The following is a description of a gene set: Human Gene Set: HP_GENERALIZED_MUSCLE_WEAKNESS Generalized muscle weakness studied in species Homo sapiens Generalized weakness or decreased strength of the muscles, affecting both distal and proximal musculature., and this is the list of marker genes: SDHAF1, HADHB, AARS2, PON1, CLCNKB, MAP3K20, RNU12, LAMB2, BAG3, TAF15, VCP, MYH7, SLC2A3, TTN, CAPN3, HTT, SLC16A2, MORC2, AIFM1, RYR1, SLC25A1, PLOD1, CHMP2B, HADHA, FKRP, COL12A1, MATR3, SCN4A, RANBP2, ANXA11, COLQ, CHAT, GAA, VAPB, TBK1, SYT2, PNKD, COL6A2 (NCBI Gene Id 1292), COL6A1, DSE, DAO, KLHL41, ANG, RAPSN, ERBB4, ITGA7, MEN1, MEGF10, NEK1, LDB3, CFAP410, MYO9A, PLEC, POMT1, ACAD9 (NCBI Gene Id 96656), TARDBP, MTM1, ABCB6, FIG4, PLA2G6, SLC12A3, SQSTM1, CCND1, EXOSC9, SLC5A7, CRPPA, CAVIN1, SELENON, SLC18A3, COL13A1, CCNF, VAMP1, CHRNA1 (NCBI Gene Id 1134), SNAP25, POLG, PRRT2, TWNK, SLC52A3, COL6A3, COA8, SPTLC1 (serine palmitoyltransferase long chain base subunit 1), PON3, UBQLN2, PFN1 (NCBI Gene Id 5216), MYL2, ATP13A2, UNC13A, ORAI1, ADCY5, TREM2, ATXN2, UBA1, HNRNPA1, POMT2, DMD, CHCHD10, FGF23, YY1, FKTN, PRPH, PPARGC1A, MYH2, KCNJ1, DNAJB6, SLC25A4, SLC12A1, SDHB, PIGN, SOD1, HACD1, LMOD3, FUS, TPM2 (NCBI Gene Id 7169), SDHA, DCTN1, FXYD2, ACTA1, MUSK, SDHD, NEB, GLT8D1, OPTN, GLE1, TK2, AGRN, ACY1, MYL1, NEFH (neurofilament heavy chain), PON2, TPM3, AGK, POMGNT1, IBA57, CHRND